The following is a description of a gene set: from publication Hervas-Stubbs S, Riezu-Boj JI, Gonzalez I, Mancheño U, Dubrot J, Azpilicueta A, Gabari I, Palazon A, Aranguren A, Ruiz J, Prieto J, Larrea E, Melero I (PMID 21108462) species: Homo sapiens Genes down-regulated in CD8 T cells: control versus stimulated by IFNA2 and activated by anti-CD3 and anti-CD28. IFN alpha mediated gene expression pattern. The effect of IFN alpha on human CD8 T cells responding to antigen (signal 1) and costimulatory signals (signal 2) provided by beads coated with anti-CD3 and anti-CD28 mAbs. This analysis examined the effects of IFN alpha on human CD8 T cells responding to antigen (signal 1) and costimulatory signals (signal 2) provided by beads coated with anti-CD3 and anti-CD28 mAbs. Magnetically sorted untouched CD8+CD45R0- T cells from three different donors were unstimulated or stimulated with IFNa2b or with anti-CD3/CD28 Beads alone or along with IFNa2b or IFNa5 for 48 hours. Individual mRNA samples were analyzed using HG-U133A 2.0 array gene chips. Human Gene Set: GSE17301_CTRL_VS_48H_ACD3_ACD28_IFNA2_STIM_CD8_TCELL_DN, and this is the list of marker genes: DEPDC1, MBNL3 (muscleblind like splicing regulator 3), DAPK1, LIMK2, CDR1, MRPL28, ACSBG1 (acyl-CoA synthetase bubblegum family member 1), MAP2K7, PLS1, CEP295, RRM2, AAAS, E2F3, H1-5, CENPM, CIAO3, ORAI2, TROAP, SETBP1, GPR19, TNFAIP2, SPPL2B, PIMREG, POLH, SH3GL3, RAD54L, SLC1A5, NMU, DBF4B, ETV7, EMID1, MVD, AKIP1, DND1, NEIL1, NEFH, MFGE8, RUSC1, CR2, MXD3, TUT1, KPTN, CD1E, FKBP4, TYMS, CPPED1, DOHH, HSPBP1, CDK1, ANKRD36BP2, SCARB1, EXO1, POLG, DENND3, MAST2, AKAP3, ZW10, TSPOAP1, TP53I11, CCHCR1, LMF2, CLDN5, PTPA, CLSPN, CC2D1A, CDKN2C, NAA40, H2AC15 (H2A clustered histone 15), NUDT11, XYLB (xylulokinase), ITGA7, ZNF646, HDAC7, CLIP2, TAF15 (TATA-box binding protein associated factor 15), RUBCNL, CD1B, STK11, SLC1A4, RTEL1, FOXM1, HAUS5, BRCA1, EPN1, RAG1, HOXA10, ATAD5, SLC25A10, HOXA7, TOMM40, PTK7, KCNJ4 (potassium inwardly rectifying channel subfamily J member 4), FSTL1, MICAL3, FAAP24, RASSF1, PTGDR2, HMGN2, RHOT2, CNPY4, PIGZ, SLC29A1, FGR, PCLAF, IQCC, LCT, MELK, GSS, HMGB2, HMGB1, ZNF337, PTTG1, RNASEH2B, GTSE1, GUCY1B1, SREBF2, TK1, F2R, ZNF500, HSD17B6, CEP85, PTDSS2, DCLRE1B, PCBP3, PLEKHA5, NUSAP1, CAPN10, CTNNAL1 (NCBI Gene Id 8727), TRAIP, WDR62 (NCBI Gene Id 4181), E2F1, AEBP1, TLE6, TNFRSF21, RAB32, STK32B, LRRC61, H2BC14, GCAT, MZB1, SFN (stratifin), FPGS, CD1A, CD1C, CDC42EP3, FASTK, CIC, PRRC2A, GFI1 (NCBI Gene Id 2672), CD8A, GLA, INSR, SEPTIN8 (NCBI Gene Id 23176), RTL10, CDK5RAP2, CD8B (CD8 subunit beta), ARL4A, FXYD2, PINLYP, CDCA3 (NCBI Gene Id 83461), ATP2A1, DNMT3B, NCAPH2, GOLGA2P5, RORC, KDM5C, H4C1, CD99, MUC16, ANGPTL3, PIWIL1, CCNF, CCNB2, H4C3, CEP164 (NCBI Gene Id 22897), PTGES2, MAGOH2P, CIT, ASF1B, KLHL23, CD72, ORC6, RECQL4, PKMYT1, TTLL3, MAP1A, HMGB3P1, LST1, TERT, DNTT, FADS2, APOM, HJURP, TST, EFNB2, RAC3, MAP3K20, HADH, SPON2 (NCBI Gene Id 10417), MYBL2